Given this list of marker genes Sco1, Ppdpf, Tgfbr3, Cdkn2a (cyclin dependent kinase inhibitor 2A), Frzb, Vtn, Ptn, Gfer, Cpt1a, Cfc1, Itga2, Mesp1, Errfi1, Klf1, Ccnd1, Hfe, Pnpt1, Lims1, Nodal, Baat, Smo, Ptpn3, Pkd1, Ptch1, Il18, Hnrnpd, Ccdc40, Cpb2, Mks1, E2f7, Upf2, Il6, Icmt, Cldn1, Pck2, Rela, Cad, Hnf4aos, Mki67, Mrtfb, Lipa, Cd2ap, Cebpa, Pik3ca, Rps6ka1, Nipbl, Hhex, Ugt1a7c, Bmp4, Med1, Zmpste24, Npc1, Jun, Hmbs (NCBI Gene Id 97580), Meg3, Rpl10, Hnf1a, Ceacam2, Ldha, Rara, Sox17 (SRY (sex determining region Y)-box 17), Cebpg, Ada, Plau, Ccdc39, Foxa3, Fgl1, Aurka, Smarca4, Asns, Cyp1a1, Onecut1, Fgf18, Csnk2a1, Upb1, Ezh1, Dnaaf1, Man2a1, Fgf1, Tnfaip3, Xbp1, Tet2, Hnf1b, Atg7, Mdk, Otc, Hmgcs2, Vwf, Pcsk9, Onecut2, Ifng, Atf2, Arf6, Cflar, Rcbtb2 (regulator of chromosome condensation (RCC1) and BTB (POZ) domain containing protein 2), Pkm, Reg1, Rhbdd3, Ift88, Prox1, Ahr, Acat1, Ass1, Slc7a5, Wnt4, Tbx3, Il10, Met, Elk1, Jarid2 (jumonji and AT-rich interaction domain containing 2), Sp3, Foxh1, Cp, Gli1, Proc, Aldh1a2, Rb1cc1, Taf10, Hpcal1, Pcna, Rgn, Hgf, Sod2, Tgfb1, Hmox1, Igf2r (NCBI Gene Id 16004), Serpina10, Notch1, E2f8, Pkd2, Lsr, Sox9, Ptcd2, Gata6, Hlx, Acadm, Hpn, Sp1, Itpr1 (NCBI Gene Id 18544), Foxm1, Gli3, Sulf2, Cited2, Ucp2, Aco2, Ugt1a9, Ugt1a1, Tnf, Slco1b2, Cobl, Cul3, Dut, Smarcb1, Prkcsh (NCBI Gene Id 19089), Naglu, Nphp3, Aacs, Runx1, Cdkn2b, Cadm1, Wnt1, Atf7, Ceacam1, Nf1, Hspa12a, Mpst, Zic3, Pdx1, Ggt1, Cdk5rap3, Hp, Tyms, Fpgs, Hes1, Smad3, Pck1, Gak, Ugt1a8, Egfr, Asl, Cps1, Notch2, Cebpb, Rtn4, Tgfa, Rpgrip1l, Stat5b, Lims2, Ezh2, Wnt3a (wingless-type MMTV integration site family, member 3A), Sec63, Mir30a, Ihh, here is a description of the gene set: The progression of the hepaticobiliary system over time, from its formation to the mature structure. The hepaticobiliary system is responsible for metabolic and catabolic processing of small molecules absorbed from the blood or gut, hormones and serum proteins, detoxification, storage of glycogen, triglycerides, metals and lipid soluble vitamins and excretion of bile. Included are the synthesis of albumin, blood coagulation factors, complement, and specific binding proteins. Mouse Gene Set: GOBP_HEPATICOBILIARY_SYSTEM_DEVELOPMENT studied in species Mus musculus